The following is a description of a gene set: species: Mus musculus Any process that modulates the frequency, rate or extent of the error-free repair of a double-strand break in DNA in which the broken DNA molecule is repaired using homologous sequences. Mouse Gene Set: GOBP_REGULATION_OF_DOUBLE_STRAND_BREAK_REPAIR_VIA_HOMOLOGOUS_RECOMBINATION, and this is the list of marker genes: Polq, Cgas, Shld1, Actl6a, Mad2l2, Rnf126, Setd2, Ooep, Fignl1, Vps72, Was, Epc1, Wrap53, Recql5, Fbh1, Actr2, Brd8, Pias4, Ubqln4, Arid2, Parpbp, Yeats4, Csnk2a1, Trrap, Helb, Epc2, Usp51, Ing3, Fancb, Radx, Rad51ap1, Rtel1, Mbtd1, Klhl15, C1qbp, Chek1, Morf4l2, Kat5, Rmi2, Tex15, Abl1, Senp3, Crebbp, Helq, Ercc6, Rif1, Wdr48, Rnf8, Fus, Skp2, Sirt6, Dmap1, Zfp365, Trp53bp1, Prmt1, Hdgfl2, Blm, Mrgbp (MRG/MORF4L binding protein), Mrnip, Morf4l1, Ruvbl2, Kdm1a, Peli1, Ruvbl1, Terf2ip, Rpa2, Parp1, Smchd1, Rad51, Meaf6, Kmt5a, Spidr, Ep400, Khdc3, Shld3 (NCBI Gene Id 113002583), Actb, Shld2, Timeless, Plk1, Ppp4c, Ppp4r2